The following is a description of a gene set: Any process that stops, prevents, or reduces the frequency, rate or extent of the directed movement of proteins from the nucleus into the cytoplasm. studied in species Mus musculus Mouse Gene Set: GOBP_NEGATIVE_REGULATION_OF_PROTEIN_EXPORT_FROM_NUCLEUS, and this is the list of marker genes: Txn1, Bard1, Fam76b, Cdk5, Park7, Sp100, Rangap1 (NCBI Gene Id 97970), Hdac3